The following is a description of a gene set: Mouse Gene Set: REACTOME_DCC_MEDIATED_ATTRACTIVE_SIGNALING DCC mediated attractive signaling species: Mus musculus, and this is the list of marker genes: Dcc, Trio, Cdc42, Rac1, Dock1, Src, Ptk2, Fyn, Nck1